The following is a description of a gene set: Human Gene Set: GSE369_PRE_VS_POST_IL6_INJECTION_SOCS3_KO_LIVER_UP Genes up-regulated in liver from SOCS3 knockout: untreated versus IL6 injection. from publication Croker BA, Krebs DL, Zhang JG, Wormald S, Willson TA, Stanley EG, Robb L, Greenhalgh CJ, Förster I, Clausen BE, Nicola NA, Metcalf D, Hilton DJ, Roberts AW, Alexander WS (PMID 12754505) species: Homo sapiens Changes in mouse liver mRNA profiles following intraperitoneal cytokine injection. Either interferon-gamma-/-, albumin-cre(-) Socs3(w/fl) mice, or albumin-cre(+) Socs3(-/fl) mice were injected with either phosphate-buffered saline, interferon-gamma, or interfeukin-6, and livers taken after 4h., and this is the list of marker genes: PLAAT4, ZNF267, GEM, BACH1 (BTB domain and CNC homolog 1), PPFIA1, TOX4, TMED2, RBPJ, OSMR, ADORA2B, ELOVL2, EMC1, E2F5, PAPOLA, EYA2, SUN2, CD53, CDC5L, EIF1, SLC20A1, MAGOH, GATA6, ATP2B1, TNFSF11, DDIT3, ITGB7 (integrin subunit beta 7), CRIP1, SLC31A2, BNIP3L, CCDC144A, ARPC2 (actin related protein 2/3 complex subunit 2), FSTL1, CLDND1, IARS1, RPS29, MTHFD2, SHOC2, YWHAQ, PGK1, BCL2A1, FCGR1A, CCRL2, ELF1, CYP2C19, NMB, PHLDA2, EIF2S2, SERPING1, TES, PPARG, RIOK3, CD44, MORF4L2, ATF4, HNRNPH1, CLK1, HBP1, ING3, CEBPG, MCL1, KLF6, H2BC4, STARD8, CYTIP, SEC11A, RGS13, WARS1, RPL31, RHEB, ICAM2, CD55, RPL7, GNG5, IL1RL1, BNIP2, PRNP, MAFF, SNAPC1, ADGRG2, KLF10, MIR22HG, DIAPH1, MID2, RALB, P2RY10, DUSP4, CHD1, PTPRE, UBE2D3, RNF139, FEM1C, DYNC1LI2, ENO2, AQP9, EIF5, PHLPP1, CD63, TARS1, STRN3, RPL36AL, LDHA, NR3C1, SLC2A3, ADGRE5, ADIPOQ, TGIF1, S100A10, ABL2, TXN, RBM3, RPL23A, IFNG, RAB1A, MAP1LC3B, CHMP2B, TMED5, HK2, APOH, RPS25 (ribosomal protein S25), RPS21, SERPINA1, SLC12A2, CDS1, ANKRD28, NR2C2, RPS19, JUN, SPP1, SNRK, ZBTB43, CFHR2, PFDN4, VAMP5, GK, HECW1, EMP1, RPL23, BTG1, HSPA13, GPSM2, MCFD2, CD1C, NUP50, RRN3, PLIN2, DUSP10, RP2, CTNNAL1, NPY1R, RAF1, PGAM1, TTN, CDKN1A, B2M, POU4F1, TSC22D3, KLHL21, ADO, UBE2J1, ARF6, P4HA1, NUP58, PAFAH1B2, NPC1, ADAM19, S100A8, GLA, PAPSS1 (NCBI Gene Id 9061), PSME2, RPS11, SLC2A5, RPL9 (NCBI Gene Id 6133), CCND2, BHLHE40, RUFY3, ETS2, CFLAR, FBP1, SYF2, ANXA2P1, IFRD1, PKP1, MOAP1, CRADD, ARID5B, GALNT3, RPL24, ADCY3, MKLN1, SERTAD2, MEIS3P1, CKS2 (CDC28 protein kinase regulatory subunit 2), EZR, GARS1, RPS15A, CPB2, HSPA1A, NET1 (neuroepithelial cell transforming 1), RAPGEF2